Given this list of marker genes Kcnj12, Grin2a, Kcne5, Cacna1h, Clcn4, Kcnh1, Kcnh5, Grin2d, Kcnh2, Tmem37, Kcnh4, Kcnj14, Kcnk1, Kcnt1, Kcnf1, Tmem109, Tmc4, Kcns1, Catsper3, Kcnj2, Cacna1i, Kcna2, Kcnip2, Cacna1d, Cacng1, Hcn1, Tmc2, Clcn1, Htr1b, Kcna1, Kcnj6, Kcnn4 (potassium intermediate/small conductance calcium-activated channel, subfamily N, member 4), Kcne4, Kcnk16, Cacng3, Cacna2d2, Kcnq2, Kcnd2, Clcnka, Clcn2, Kcnk9, Tmc1, Hcn2, Grin1, Slc17a3, Kcne2, Catsper2, Cacna1c, Kcnk2, Kcns2, Kcnn1, Kcnh6, Kcnj13, Kcna5, Snap25, Hcn4, Scn1a, Cnga2, Grin2b, Kcnc4, Kcnq4, Kcnk7, Kcnab2, Catsper1, Trpa1, Kcna7, Kcnk4, Vdac1 (voltage-dependent anion channel 1), Cybb, Tmem266, Cacnb1, Lrrc52, Kcnq1, Kcnh3, Hvcn1, Rimbp2, Ncs1, Kcnb1, Lrrc26, Clcn3, Kcnd1, Scn10a (NCBI Gene Id 208230), Cacna2d3, Kcnv1, Kcnj3, Kcnk13, Calhm6, Kcns3, Cachd1, Tpcn2, Lrrc38, Vdac3, Kcnv2, Kcnd3, Kcnmb4, Kcnh8, Kcnc2, Cacng7, Cacna1a, Cacnb4 (NCBI Gene Id 73120), Kcnk12, Tspoap1, Cacna1e, Kcnq3, Kcng3 (potassium voltage-gated channel, subfamily G, member 3), Ano1, Kcne1, Clcn5, Kcnk10, Kcnj5, Tpcn1, Kcnb2, Kcnj9, Kcnh7, Itgav, P2rx5, Lrrc55, Kcnab3, Cacnb2, Kcnma1, Kcnj11, Lrg1, Kcnj1, Ryr1, Kcnt2, Cacna1s, Kcnj4, Kcna10, Catsper4, Cacna2d1, Kcnn3, Kcna6, Scn2a, Cacnb3 (calcium channel, voltage-dependent, beta 3 subunit), Oprm1, Kcnk5, Calhm1, Grin2c, Kcnc3 (NCBI Gene Id 16504), Kcna3, Kcne3, Kcna4, Kcng1, Vdac2, Grin3b, Cacna1b, Kcnj15, Kcng4, Cacng2, Kcnk18, Grm7, Clcn6, Gpr89, Cacna1g, Kcnq5, Cacng8, Cacng4, Kcnab1, Kcnc1, Kcnn2, Ano6, Calhm3, Scn2b, Kcnk3, Cacna1f, Kcnj8, Kcnj16, Clcnkb, Grin3a (NCBI Gene Id 83489), Trpm4, Kcnk6, Kcnj10, Cav1, Pkd2, Cacna2d4, Cacng5, Hcn3, here is a description of the gene set: species: Mus musculus Mouse Gene Set: GOMF_VOLTAGE_GATED_CHANNEL_ACTIVITY Enables the transmembrane transfer of a solute by a channel whose open state is dependent on the voltage across the membrane in which it is embedded.